The following is a description of a gene set: studied in species Mus musculus Mouse Gene Set: GOMF_CHROMATIN_INSULATOR_SEQUENCE_BINDING Binding to a chromatin insulator sequence, a DNA sequence that prevents enhancer-mediated activation or repression of transcription., and this is the list of marker genes: Ctcfl, Zfx, Zfp276, Repin1, Zfp692, Ctcf